Given this list of marker genes SIPA1L3, CD8A, ATG2A, TIMELESS, GOLGA5, CITED2, CD163 (NCBI Gene Id 9332), NUTM2F, SNX5, RNASE6, PRPF39, XRN2 (5'-3' exoribonuclease 2), SLC17A8, GSN, CXCL8, RNF213, CEBPZ, GLB1L (NCBI Gene Id 79411), SENP1, LRRC4C, MICALL1, GPATCH3, BSDC1, TESPA1, PAQR5, DEXI (NCBI Gene Id 28955), MMP9, MAPKBP1, NECAP2, ZGRF1, PLEKHM2, MAL2, ELOVL2, TMEM62, ALKBH4 (NCBI Gene Id 54784), AKAP8L, COCH, AASS, FAM169A, PRDM1, CCDC85C, ALG6, ELAC1, MFSD1, ITM2C (integral membrane protein 2C), EYA3, MYL12A, MPRIP, UFSP2, PHIP, CCL11, C17orf75, PHAX, MOCOS, IL1A, CLCF1, HOMER2 (NCBI Gene Id 9455), PLEKHF2, CYP2A7, OXGR1, GEMIN7, ZDHHC2, TRIM48, CCDC81, CCL2, FMN1, SLC19A1, PAWR, BRAP, ZNF107, ZNF264, BRIP1, ILRUN, VNN1, TMEM255A, PYGB, AURKAIP1, SCARA3, TSLP, TMT1A, ZNF566, IL1RL1, HS1BP3, FABP2, PGLYRP2, NANS, LY9, POLDIP3, ZNF318, ANXA1, LAP3, CXCL10, ABHD17C, HACD1, BEGAIN, MRPL18, RRAGD, DYNC2LI1 (dynein cytoplasmic 2 light intermediate chain 1), WDR46, TMEM250, GABPB1-IT1, ELOB, MST1R, C1orf116, PLGLB2, TMEM161A, CHD9, UGCG, REPIN1, DCAF15, CYP1A1, MXRA8, SOX6, RPRM, ZCCHC4, CEP162, ADIPOR2 (NCBI Gene Id 84751), ARID5A, FBXO11, ESPN, SPNS1 (NCBI Gene Id 83985), GPR26, ZNF143, KDM5B, DNAJA1P5, MCMBP, EPS15L1, TLN1, NFIL3, CCDC90B, CST1, LEPROTL1, EREG, PPP4R2, USP36, MRPS15, BGN, ZFP41, PDCD6, MAPK4, CELP, TIMP4, SARAF, CCAR2, GJC2, OR7E12P, SV2B, TUBA4A, YWHAB, HBE1, CUL9, ANKRD13A, COPE, ARHGAP45, LACTB, SLITRK1, TMEM120A, NACAD, GEM, LINC00160, PDCD2L, SLMAP, ATG16L1, PAPOLA, DCANP1, KLHL41, TDP1, AMY2B, WDR19, CELF2, CACNA2D3, PTPRZ1, GRAPL-AS1, CYYR1, ERLIN2, PIP4K2C, ATXN7, CHST9, SCD, NADSYN1, QKI, APTX, ACE, OBSCN, CCBE1, NEPRO, DLC1, RNF103, MBD5, ERVMER34-1, KRT19, STAT3, FBXW4, MOB4, AHNAK, FAM220A, CLUH, BCL2L13, NME1, PNMA8A, SAV1, DIRAS2, MRPL27, PARS2, FGFR1, FN1, LRP3, BFSP2-AS1, CCDC134 (coiled-coil domain containing 134), KLHL4, ARHGAP15 (NCBI Gene Id 55843), CIP2A, MMP14, CHD1, MMP7, LDAH, KAT2B, ACSL1, NELFCD (negative elongation factor complex member C/D), SLC22A3, MLYCD, TBC1D9, WRNIP1, STRN, TOR4A, EARS2, ZMAT4, TFPI2, MAP2K6, BAG3, SSBP4, ZNF117, GPSM3, CHL1, TMEM248, BCL2L14, SMG7, PCED1B, SDC3 (syndecan 3), RERE, SQOR, ACVR1, NOP53, LARP1, CDH4, VIT, ATRN, HNRNPDL, SPSB4, ACTR6, CNOT6L, ITGB5 (integrin subunit beta 5), ISYNA1, LYL1, MORC3, GOLGA4, ASXL2, EPHA7, TAL1, NGF, CCNL1, KIAA2013, GJA1, LYZ, TP53, ITK, KCNE4, MCTS1, NEIL1, PTGS2, GPR68, DZIP3 (NCBI Gene Id 9666), ITGB1, CDK16, SUGP2, LANCL2, GJA5, OR2A1, SMAD3, AMIGO1, PDE4D, NCF2, ANKFY1 (ankyrin repeat and FYVE domain containing 1), ATP8A2, SLC11A2, CD1A, POU6F2, BTN2A1, RBM7, SURF6, BAIAP3, MED25, MREG, REV3L, PTPRT, ART3, FPR2, TNFRSF13C, HMGN5, FNBP4, MED28, NRL, TMLHE, SNRNP25, NOL7, MED12L, ACSM5, SP140L, AMZ2, RNASEL, NXPH4, TMEM144, KATNAL1, DNAAF4, EIF2B4, CDK11A, FAIM, SLAMF7, CAND1, EPB41L4B, PI4K2B, PIF1, ZBTB5, CSF2RB, SFRP1, PRDM8, CSF1, OSBPL9, TMEM121B, FOS, SIAH1, TMED3, TMCC2, DCTN3, ERMN, LRRC19, STRIP2, CHST1, INO80B, PLEKHG1, CMTM6, ZMYM5, TRIM7, ZKSCAN7, FGD6, FAF1, IL18R1, QSER1, MTMR12, SLC26A8, CORIN, XPO4, FURIN, KATNIP, TTF2, DES, DDX60, LMTK3, UNC79, NR2E1, POGLUT2, TMEM97 (NCBI Gene Id 27346), TRABD, RPAP3, NCOA7, SLC25A27, BPIFA1, CDH5, C19orf73, LNPK, IPCEF1, ITGAM, NSUN3, MAGED4B, TMEM47, KDM4D, LY86 (lymphocyte antigen 86), ACKR1, S100A5, PPP1R14D, MRPL36, DNAH11, MICB, COL6A3, TBC1D8B, SH2B3 (NCBI Gene Id 10019), RNF220, INIP, OTOR, PORCN, LRRN3 (NCBI Gene Id 92468), ATG4D, FLJ13224, CD1D, WDR25, ABI3, KLHL36, PYCR3, BASP1, SPMAP2, COQ8A, STAMBPL1, UTP11 (UTP11 small subunit processome component), NELFB, MRPL47, EPCIP, NUP54 (NCBI Gene Id 53371), HIVEP2, here is a description of the gene set: species: Homo sapiens Blood cells and cancer expression clusters. Human Gene Set: MODULE_532